Given this list of marker genes TRIAP1, GTF3C6, ZNF746, H2AB1, MAGED1, AGO2, POLR2A, ZNF771, FKBP6, RPRD1B, SUPT5H (NCBI Gene Id 6829), ZNF382, RBBP8, ARID2, CITED1, CSF1R, RABGGTB, LGALS3, ZNF732, DROSHA, PIP4K2B, EXO1, SMAD2, MTA2, ZNF790, RMI2, PPM1D, CNOT10, BCL7C, MAML3, CRCP, AFF4, TGIF2, CDKN2A, HDAC7, LMO2, YWHAZ, MT-CO1, MIR26A2, CHD4, SMARCD2, COX7B, CREB1, ZNF320 (NCBI Gene Id 162967), ZNF724, NOTCH2, KCTD1, TAF1B, NAMPT, CAT (NCBI Gene Id 847), CDC16, TRV-TAC1-1, ATR, NR4A2, ZNF727, NFIA, TNRC6B, SRC, L3MBTL1, NPY, ZNF34, RABGGTA, ZNF570, BCL6 (BCL6 transcription repressor), POLR3D, ATF2, DDX21, ZNF711, ZNF253, PPHLN1, NCOA3, SMAD6, COL1A1, ZNF250, CDK9, TAF1C, ZNF775, ZKSCAN8, TRQ-CTG1-1, GPS2, ZNF470, RSPO3, PRDX5, BOD1, BDP1, DR1, ELL3, PRMT1, ZNF737, ZNF33B, ZNF79, RNU1-1, ASH2L, MAP2K6, TAF1, INTS4, TTC5, ZNF736, TIGAR, RBM7, SMARCC2, ZNF706, POMC, ZNF20, JARID2, CNOT9, ZNF135, ZNF333, CDKN1B, PHC1, ZNF696, TFAP2E, ZNF692, ZNF273, SIRT3, ZNF442, NELFCD, PRKACA, PSMC5, TGIF1 (TGFB induced factor homeobox 1), EZHIP, ZNF282, ZNF3, GTF3C1 (NCBI Gene Id 2975), ZNF563, ZNF267, PABPN1, IFNG, YWHAH, TRR-CCG1-1, ZFP30, SMAD4, RBFOX1, MDC1, TFAP2D, WWOX, TRS-CGA1-1, ZNF500, ZNF317, H2BC15, E2F7, MOV10, TEAD4, RAD17, ZIM3, PPP2CA, ERCC2, SREBF1, ZNF793, NFIC, ITCH, POU4F1, GATAD2A, MED23, MAPK3, ZNF417 (zinc finger protein 417), JUN, PSMD8, 45S pre-rRNA gene, BRD7, ZNF213, TRS-GCT1-1, SUPT4H1, CBX4, CCNK, ZNF473, NCOA1, ZNF560, PSMB3, ZNF804B, ZNF566, TDG, PPP2CB, TRR-ACG1-1, GTF3C5, SNAPC3, IPO8, SKI, POLR3K, MED25, RRAGB, ACTL6A, SPOCD1, NR2F1, NR2C2AP, RNU12, MAX, H2BC13, TET2, miR-224, ZNF606, MAPKAPK5, TAF7 (NCBI Gene Id 93080), DYRK2, MGLL, PPP2R5C, ZNF708, ZNF14, SPI1, ZNF729, ZNF221, MTA1, ZNF726, TSC2, ZNF140, ZNF705D, INTS9, GTF2H5, ZNF350, GP1BA, MDM4, AURKA (NCBI Gene Id 8465), KAT14, BMI1, APAF1, MAPK11, ELL2, ZNF681, PCBP4 (NCBI Gene Id 57060), GTF3A, SNRPF, MLLT1 (NCBI Gene Id 56930), TRIM28, ZNF184, ZNF235, TAF3, BRIP1, MLST8, POLR2C, 5S rRNA, POU2F2, CCNT2, TAF4B, TRH-GTG1-1, TAF4, CNOT6, KRABD4, CHEK1, CASP2, DEK, CDK5R1, ZNF747, COX6B2, ZNF230 (zinc finger protein 230), BTG2, PPARGC1A, PARP1, POLR1B, SERPINE1, THRSP, SMURF1, ZNF496, DICER1, SSRP1, H2AC18, UBE2E1, TASP1, NPM1, ZNF586, CSTF3, THBS1, KMT2D, CRH, PSMD3, RNGTT, ZNF726P1, ZNF211, ERCC3, CALM1, ZNF774, ZNF420, ZNF528, PSMA5, ZFP28, MORC2, PPP2R1A, ACSL1, DPF3, ZZZ3, SSU72, ZNF556, ZNF534, ZNF354B, ZNF565, CAV1, CRADD, G6PC1, SUV39H1, ZNF559, HEY1, TDRD12, ZNF627, KRABD3, FOXG1, CTLA4, GTF2E2, SKIC8, PRKRA, ZKSCAN7, ZNF114, SP1, IWS1, OCLN, APOE, AKT2, BTG1, ZNF649, GPRIN1, INTS14 (integrator complex subunit 14), ICE1, H2AC14, RARG, BLK, SCMH1, ZFP2, CBX5, PRKAA2, SUMO2, CAVIN1, EPOP, ZNF268, ZNF714, PTEN, TXNRD1, DLL1, POU2F1, BDNF, PSMC1, ZNF430, NR4A1, RNMT, NDRG1, MAPK1, SRF, TEAD1 (TEA domain transcription factor 1), MED24, MED15, TXN, TRPC3, EZH1, ZNF510, TET1, MED17, ZNF385A, HDAC11, TP63 (tumor protein p63), ZNF441, STUB1, ZNF304, CSTF1, ZNF816, MIR137, CCND1, LPIN1, ZNF785, MAML1, NABP1 (NCBI Gene Id 64859), DPF2, HAND2, TNFRSF10A, CPSF6 (cleavage and polyadenylation specific factor 6), ZNF485, MIR132, SGF29, SETD9 (SET domain containing 9), ZNF761, ANAPC2, CPSF7, ZNF548, PRKAG1 (NCBI Gene Id 5571), PIP4K2A, GTF2A1 (general transcription factor IIA subunit 1), SMARCA5, CNOT3, UBE2S, ZNF180, ZNF517, H2BC17, MYBL1, PPP1R13L, ZNF589, MAF, CAMK4, GTF3C2, ZNF605, THRB, G6PD, ZIK1, COX8C, ZNF490, IGFBP1, ZNF792, ZNF735, BCL2L11, ZNF429, ANAPC1, PCGF2, BBC3, ZNF483, PHF20L1, BNIP3L, ZNF786, ZNF99, ZC3H8, ZNF596, TNFRSF10D, ZNF43, FOXP3, AGO4, ZNF425, HSPD1, ZNF25, MTF2, CSNK2B, GAD1, NFE2 (nuclear factor, erythroid 2), PSMD2, CHM, ZNF263 (zinc finger protein 263), ZNF124, RBBP7, CTSK, ZNF772, RNF111, CCNG2, ARID1A, ZNF37A, DPF1, COX7C, FANCC, ZSCAN25, THRA, NFYC, ZNF324 (zinc finger protein 324), AEBP2, HIPK2, RFC3, ZNF189, TAF5, ZNF713, TRL-TAG1-1, CCNG1 (cyclin G1), CHEK2, ZNF676, ATM, POLR2L, ARID1B, ZNF256, TCEA1, BID, UBTF, FOXO1, ELAC2, KMT2C, GATAD2B, PIDD1, SKP1, GTF2H3, POLR1E, CITED2, CLDN5, ING2, DDIT4, MIR378, MSX2, RARA, SLC2A3, HEY2, KMT5A, ATAD2, NFYB, CASP1, MYL9 (myosin light chain 9), ZNF675, COX5A, CTDP1, CNOT2, NR2E1, TAF12, BMAL1, RNF2, AURKB, TDRKH, ARID3A, TRP-AGG1-1, COX4I2, TWIST1, NUDT21, NOP2, TNFRSF10C, ZNF175, HSP90AA1, PLIN4, PDPK1, BRPF1, SUZ12, COXFA4, SAP30, HDAC3, POLR3C, PLK2, POLR3E, PSMC6, RHNO1, MIR23B, ZFP69B, ZNF680, ZNF546 (zinc finger protein 546), USP2, USP7, GCK, TEAD3, ZNF562, INTS7, NEDD4L, PRKAB2, INTS1, ZNF705A, SOX2 (SRY-box transcription factor 2), SLC38A9, CUL1, LIPE, GEM, ZNF703, ZNF200, CDC73, TWIST2, KRAS, PINK1, GRIN2A, ZNF143, PSMB6, TOP3A, ZNF551, TSNAX, IRAK1, ANAPC16, UBE2C, UXT, ZNF688, SCD5 (NCBI Gene Id 79966), ZNF337, ELF2, POLR2B, CDKN1A (cyclin dependent kinase inhibitor 1A), ZNF543, ZNF778, ZNF383, TMEM219, SMYD2, RBBP5, ANG, RBFOX3, SNAPC4 (small nuclear RNA activating complex polypeptide 4), CTNNB1, RPA3, SIRT1, ZNF564, 5.8S rRNA, PRMT5, PAPOLA, POLR2E, HCFC1, LAMTOR3, GLI3 (NCBI Gene Id 2737), SS18L1, YWHAG, AGO3, NOTCH4, ANAPC7, SETD1A, IL2, TRE-TTC1-1, RUNX2 (NCBI Gene Id 860), ABCA6, UHRF1, DNMT1, ZNF492, MAMLD1, GTF2F1, ZNF717, ABL1, NR1I2, ZNF17, GATA4, CCNT1, POLR2D, ZNF765, UBE2D3, SMAD1, TRP-TGG1-1, ZNF154, TAF1D, CDC23, CPAP, H2BC14, IL2RA, ZNF658B, ZNF257, ZNF738, ZNF254, AUTS2, MGA, ATXN3, FKBP5, ZFP90, ZNF519, RRAGA, HDAC1, ZFP1, ZNF100, TP53AIP1, TSC1 (TSC complex subunit 1), ZNF285, GRIN2B, TRK-TTT1-1, ZNF398, MYB, MAEL, PCGF6, ZNF620, SIN3A, RBL1, ZNF721, CD36, TOPBP1, MIR17, RNU2-1, SMARCE1, DDX4, CDK7, HDAC6, NCOR1, KDM6A, NCBP1, CDK2, ZNF214, TBL1XR1, EAF1, ZNF670, PRELID3A, SCO2, ZNF264, ZNF568, ZKSCAN1, SMAD3, CSF2, PSIP1, PSMB5, PCGF5, FABP4, LAMTOR5, SOCS3, NR3C2 (NCBI Gene Id 4306), MED8, TFDP1, ELOC, BRPF3, HIGD1C, RET, PIWIL4, TRA-AGC1-1, RUNX1, CBFB (NCBI Gene Id 9163), ASZ1, BRCA1, NUAK1, BCL2L14, CAMK2B, KANSL2, MSTN, H2BC3, POLR3A, YBX1, TRV-CAC1-1, DAXX, TFAP2A, KRABD5, MMP13, NR1H2, ZNF92, CDK13, KANSL1, ZNF860, TP53, PSMA1, TFAP2B, LMO1, E2F5, PSMB7, CPSF4, ITGA4, ANAPC4, ZNF431, TCF7L1, ZKSCAN5, MYC, H2AJ, PHF19, UBA52, RPS27A, TAF13, POLR1D, ZNF684, ZKSCAN3, RNA45S5, ZNF557, SPP1, TGFB1, CR1, ZNF33A, BCDIN3D, H2BC4, CCNA2, PIWIL1, EED, LEF1, TFAM, HCFC2, CCND3, FZR1, CBX3, ZNF514, RAD1, PSMD14, SNRPE, SGK1, SNRPD3, RFC5, H2AC6, AGPAT2, ZNF266, E2F4, ZNF433, ZNF74 (NCBI Gene Id 7625), TET3, ZNF471, ERBB2, CGB3, SESN1, REST, TNFRSF18, ZNF770, COX6A2, ZNF12 (NCBI Gene Id 7559), LEO1, CNOT8, ADRM1, POLRMT, RGCC, AKT1, ZNF561, SMAD7 (SMAD family member 7), ZNF215 (zinc finger protein 215), CDK6, RORC, XPO1, TDRD6, MED16, GPI, ZNF702P, SMARCC1, POLR2F, PLAGL1, EGFR, ZNF875, INTS2, SUMO1, PRDM7, SETD1B, GPAM, HIPK1, SKP2 (S-phase kinase associated protein 2), PSMB1, PHF1, MYBL2, TBL1X, ZNF446, CTSL, RAD51, ZNF677, GAMT, WWTR1, YAP1, NABP2, SOCS4 (suppressor of cytokine signaling 4), H2BC11, RBX1, PTPN11, MAPK14, ZNF740, PMAIP1, ZFP14, ZNF776, BRF1, INTS6, FASLG, ZNF614, PPARGC1B, ZNF75CP, ZNF555 (zinc finger protein 555), ZNF584, MED14, ZNF668, WDR82, ZNF160, MEF2C, E2F1, GRIA2, MRE11, PMS2, CEBPA, RICTOR, SERPINB13 (serpin family B member 13), NR6A1, SUPT6H, ZNF223, BCL7A, ZNF709, TAF9B, PPP1R13B, PRKAB1, GTF2E1, SEM1, KMT2A, BAZ2A, TFB2M, TRL-CAG1, TRK-TTT3-1, YEATS2, ZNF582, ZNF439, PPARG, TFDP2, RAD9B, RRAGD, TCF12, ZNF28, MED1, FAS, ZNF767P, RTF1, NR0B1, COX7A2L, TAF6, TP53INP1, MNAT1 (NCBI Gene Id 4331), ZNF157, PITX2, CDC25C, MAML2, GSR, TCF7L2, TBP, HDAC2, WRN, NR2F6, MED7, SOX9, STEAP3, HNF4G, ZNF331, SNAPC2, POLR3G, MIR302B, TASOR, PAXIP1, SAP30BP (SAP30 binding protein), MIR145, ZNF440, POLR2I, FBXO32, HTT, H3-3A, CXXC1, PSMA3, POLR2H, RRAGC, PHF20, HDAC10, SMARCB1, ZNF571, ZNF454, TNKS1BP1, ANGPTL4, SMARCD1, PCF11, KCNIP3, ACSS3, SCD, DNA2, CDK12, SMARCD3, KAT2B, ANAPC5, ZNF710, ZNF311, PSMA6, RELA, OPRK1, STK11, PAX5, H19, ZNF671, ATF7IP, ZNF169, AR, ZNF597, H2BC21, GPX2, ZNF101, ZNF224, RNU4ATAC, MED26, CSNK2A1, CCND2, CLP1, UBC, ZNF585B, POLR3H, NCOA2, TRA-CGC1-1, TARBP2, ERCC6 (ERCC excision repair 6, chromatin remodeling factor), RBL2, CPSF3, NKX3-2, PIP4K2C, SRRT, INTS10, ZNF624, RNU4-1, MT-CO3, PIP4P1, ZNF71, CAMK2G, ELOVL5, ZNF468, ZNF354A, NR5A2, COX5B, BGLAP, TP53RK, CNOT6L, ZNF782, POLR2J, RRP8, ITGBL1, ZNF347, ATRIP, RB1, RAN, FANCI, CDK5, GAD2, TCF7, RBBP4, MED10, MIR675, ZNF705G, CAMK2A, GATA2, PVALB, JUNB, SS18, VEGFA, ZNF18, ARNT, TAF11, NPPA, ZNF626, ZNF707, POLR1H, ZNF70, ZNF419, POU4F2, TP53BP2, UBB, ZNF112, TGFA, ZNF599, MIR24-2, COL1A2, PAF1, ZNF730 (zinc finger protein 730), ZKSCAN4, SNRPB, HNF4A, ZNF700, ELOA, TNRC6A, CIDEC, MED4, NELFB, NOTCH3, CDC27, TAF7L, SKIL, PTPN1, TAF1A, MLLT3, ZNF840P, PSMB2, DNMT3B, EP300 (NCBI Gene Id 2033), ZNF839, NCBP2, NR1I3, TAF9, CDC7, PML, SESN3, RYBP, MIR20A, MTOR, NR4A3, NELFE, RNU11, TCF3, LBR, BARD1, RPRD2, CDK4, ZNF662, ZNF484, H2BC9, TXNIP, LSM11, KCTD6, ZNF202, PLD6, YWHAE, PHAX, MIR215, UBE2D1, E2F8, NR1H3, TRA-TGC1-1, SAP30L, POLR1G, ZNF616, ZNF287, ZNF529, TRE-CTC1-1, TAF1L, CASP10, SUDS3, ZNF234, COX7A1, CTR9 (NCBI Gene Id 9646), MBIP, ZNF554, ZNF75A, PCNA, MYO1C, ZNF799, NR1D1, ZNF621, GTF2H4, RPRD1A, POLR1F, RXRA, RBM14, ZNF212, LAMTOR4, ZNF544, GLS2, GTF2H2, ACTL6B, TAF2, GTF2H1, RRM2B, ZNF479, CCNC (NCBI Gene Id 892), ADIPOQ, NFKB1, ZNF480, INTS3, RPAP2, ITGAL, BCL7B, SOD2 (superoxide dismutase 2), SP7, CSNK2A2, PPP2R1B, ZNF625, UBE2I, ZNF225, PRELID1, RPTOR, FANCD2, C19orf84, RAD51D, SMARCA2, TRIM63, MED13, LAMTOR2, EAF2, CDKN2B, PSMA7, YY1, RNF34, NR1H4, TRG-CCC1-1, ZNF595, POLR2G, BRF2, ZNF521, IL6 (interleukin 6), ZNF583, ZNF2, ZNF354C, INS, ZNF394, SFN (NCBI Gene Id 2810), ZNF699, RNU5A-1, MED20, RFFL, ZNF222, EZH2 (NCBI Gene Id 392834), NR2C2, IGFBP3, ZSCAN32, GATA3, ZFP69, ZNF274, TADA2A, PSMB4, H3C1, MBD3, MOV10L1, ZNF30, ZNF141, CBX8, ACTB, MEN1, MIR24-1, H4C1, AIFM2, LIFR, RFC2, RETN, ZNF585A, ZCCHC8, POLR3B, ZNF75D, PSMC3, ZNF791, PGR, ZNF716, SATB2, RORB, CSTF2, PAGR1, PRKAA1, TBX5, ZNF445, CCNA1, MLH1, PSMA2, ATP1B4, KMT2B, CGA, NCOR2, POLR2K, NFIX (nuclear factor I X), ARID4B, TRV-AAC1-1, LAMTOR1 (late endosomal/lysosomal adaptor, MAPK and MTOR activator 1), PF4, NR1D2, ZNF549, ZNF45, ZNF749, H2AC7, ZNF577, ZNF426, MEAF6, HDAC4, GTF2A2, ZNF613, ZNF136 (NCBI Gene Id 7695), PEX11A (peroxisomal biogenesis factor 11 alpha), CDK8, TRIM33 (NCBI Gene Id 80027), PRKCQ, SNAPC5, DNMT3L, CDK1, LDB1, ZNF658, CCN2, MTREX, COX4I1 (NCBI Gene Id 1327), ZNF436, DGCR8, BRD1, AKT3, SAP130, ANAPC11, CYCS, NR5A1, DPY30, ZNF641, YWHAQ, CASP6, POLR3F, MBD2, ZNF286A, ZNF697, ZNF587, ZNF610, NOC2L, BAX, MED30, ELL, H2BC12L, ZNF443, H2BC26, TNRC6C, LPL, ZNF248, NCOA6, ZNF10, ICE2, PDK4, CREBBP, ITGA5, TRI-TAT1-1, RAD50, PRKCB, GTF2F2, ZNF418 (zinc finger protein 418), MYBBP1A, ZNF41, RFC4, KLF4, FOXO3, ZNF607, RXRG, ZNF569, AGO1, H2AC20, PLIN2 (perilipin 2), SYT10, USP9X, ZNF705EP, WDR33, CARM1, RMI1, ZNF133, RHEB, YES1, PCK1, PSMD12, HDAC5 (histone deacetylase 5), ZNF227, AXIN1 (NCBI Gene Id 8312), NFIB, GLI2, MET, GTF2B, PSMD7, HIVEP3, ZNF619, ZNF155, PSMC4, ESRRA, CDC26, TEAD2, ZNF689, MDM2, ZNF205, PLXNA4 (plexin A4), MED12, RING1, STAT1, 18S rRNA, 5.8S rRNA, 28S rRNA, TTF1, ZNF506, COX6A1, WDR5, BANP, ZNF26, BOD1L1, ANAPC10, CPSF2, TFAP2C, OPRM1, FIP1L1, CAMK2D, IHH, NPAS4, NRBP1, OGT, RUNX3, H2BC12, JAG1, ZNF547, HDAC9, ZNF23, H2AZ2 (NCBI Gene Id 94239), ZNF415, VENTX, JMY, ZNF682, ZNF343, RORA, INTS5, ZNF704, CITED4, RPA1, IQSEC3, NR3C1, ZNF302, H2AX, GLS, CPSF1, CHD3, TAF10, YEATS4, RBPJ, PTPN4, AJUBA, PRKAG3, E2F6, ZIM2, ZNF460, POLR1A, COX7A2, TRG-GCC1-1, TP73, FOXO4, ZNF667, ESR1, PPM1A, MTERF1, ZNF773, KIT, ZNF334, DDB2, ZNF664, PSMD1, EHMT1, HUS1, COX8A, INTS11, RRN3, TRM-CAT1-1, MOBP, MT-CO2, ZNF611, CNOT4, SNW1, RRM2, INTS12, GSK3B, ZNF195, ZNF701, TP53I3, KAT6A, KCTD15, UCMA, CCNE2, TAF8, TRD-GTC1-1, ZNF600, KAT8, DDIT3, DNMT3A, LSM10, INTS13, IL3, FURIN, ZNF77 (NCBI Gene Id 7630), PERP, ESRRB, H2AC4 (NCBI Gene Id 8335), HES1, ZNF416, POLR1C, ZNF777, ZNF550, ZNF660, ZNF197, VDR, MSH2, ELOA2, CTSV, YWHAB, BMP2 (bone morphogenetic protein 2), ZFPM1, SNRPG, ZNF665, ZNF764, NLRC4 (NCBI Gene Id 58484), H3C15, NBN, PNPLA2, ZNF750, SESN2, SYMPK, PRMT6, MCRS1, TPX2, KDM5B, KAT2A, WWP1, L3MBTL2 (L3MBTL histone methyl-lysine binding protein 2), CEBPB, CBX2, PPARA, PHC3, AKAP8L, H2BC5, NOTCH1, 28S rRNA, ZNF93, ZNF552, MIR18A, ZNF432, ZNF540, MED27, ZNF300, NELFA, CCNH, CCNE1, ING5, EHMT2, NR0B2, PHC2, TSN, INTS8 (integrator complex subunit 8), MIR27A (NCBI Gene Id 407018), ZNF678, PLIN1, ESR2, ITGA2B, ANAPC15, RARB, YAF2, COX6C, BIRC5 (baculoviral IAP repeat containing 5), XPO5, AGRP, GATA1, ZFP37, PIWIL2, TDRD9, RAD9A, SAP18, SSB (NCBI Gene Id 6741), NR2C1, MECP2, ZNF530, DLX6, SETDB1, SST, SF3B1, PBRM1, ELF1, SUPT16H, PHLDA1, FOXO6, TNFRSF10B, MAPKAP1, TJP1, TAL1, ZNF493, MPHOSPH8, NFATC2, PSMC2, RPA2, ZNF208, CCNB1, MTA3, RXRB (retinoid X receptor beta), ZNF718, KAT5, ZNF461, PIN1, PSMA4, PRDX1, CNOT7, ELOB, MIR26A1, SLBP, TADA3, KANSL3, ZNF486, PLK3, CNOT11, PRR5, PSMD13, ARNT2, ZNF679, ZNF324B, BAZ1B, CBX6, BRD2, PRDM1, ZFHX3, ZNF19 (zinc finger protein 19), ZNF615, MED6, ZNF558, FOS, ZNF138, SNAPC1, TAF15, NR2E3, ZNF567, HDAC8, POLR3GL, PSMD6, CSTF2T, SMURF2, ESRRG, TDRD1, SMARCA4 (SWI/SNF related, matrix associated, actin dependent regulator of chromatin, subfamily a, member 4), NRBF2, ZNF226, COX6B1, ZNF233, SIN3B, MED31, BLM, GTF3C4, ZNF691, DLX5, ZNF669, EPC1, DGAT2, H2BC1, MIR106A, PPARD, ZNF573, CNOT1, HENMT1, NKX2-5, GTF3C3, PRKAG2, PRDX2, NFYA, PSMD11, ZNF655, GADD45A, here is a description of the gene set: Gene expression encompasses transcription and translation and the regulation of these processes. RNA Polymerase I Transcription produces the large preribosomal RNA transcript (45S pre-rRNA) that is processed to yield 18S rRNA, 28S rRNA, and 5.8S rRNA, accounting for about half the RNA in a cell. RNA Polymerase II transcription produces messenger RNAs (mRNA) as well as a subset of non-coding RNAs including many small nucleolar RNAs (snRNA) and microRNAs (miRNA). RNA Polymerase III Transcription produces transfer RNAs (tRNA), 5S RNA, 7SL RNA, and U6 snRNA. Transcription from mitochondrial promoters is performed by the mitochondrial RNA polymerase, POLRMT, to yield long transcripts from each DNA strand that are processed to yield 12S rRNA, 16S rRNA, tRNAs, and a few RNAs encoding components of the electron transport chain. Regulation of gene expression can be divided into epigenetic regulation, transcriptional regulation, and post-transcription regulation (comprising translational efficiency and RNA stability). Epigenetic regulation of gene expression is the result of heritable chemical modifications to DNA and DNA-binding proteins such as histones. Epigenetic changes result in altered chromatin complexes that influence transcription. Gene Silencing by RNA mostly occurs post-transcriptionally but can also affect transcription. Small RNAs originating from the genome (miRNAs) or from exogenous RNA (siRNAs) are processed and transferred to the RNA-induced silencing complex (RISC), which interacts with complementary RNA to cause cleavage, translational inhibition, or transcriptional inhibition. Reactome Pathway: Gene expression (Transcription) species: Homo sapiens